Given this list of marker genes PLA2G2F, PLA2G10, PLA2G4A, PLBD1, PLA2G5, PLA2G12A, PLA2G2E, PLA2G4F, PLA2G2D, PLA2G4E, PLAAT3, PLA2R1, PLA2G1B, MBOAT7, PLA2G4C, PLA2G2A, PLA2G4D, here is a description of the gene set: Acyl chain remodelling of PI species: Homo sapiens Human Gene Set: REACTOME_ACYL_CHAIN_REMODELLING_OF_PI